Given this list of marker genes MYH3, MYL4, MYL9, MYO3A, MYO7B, MYH9, MYL3, MYO19, DYNLL2, MYO1G, MYH7B, MYH2, MYH16, MYH10, MYH14, MYO1E, MYO1H (myosin IH), CGN, MYH7, MYH11, MYO9A (myosin IXA), MYO9B, MYL5, MYO6, MYH4, MYL7, MYO5A, MYO1F, LIMCH1, MYL12A, BMF, MYO10, MYO5B, MYL11, MYO1C, MYO15A, MYH8, MYH15, MYO7A, MYO18B, MYL6, MYO16 (NCBI Gene Id 23026), CGNL1, MYH6, MYH13, MYH1, MYO1A, MYO5C, MYO1B, MYL12B, MYO3B (NCBI Gene Id 140469), MYL6B, MYO1D, MYL2, CCDC102A, MYL1, MYO18A, here is a description of the gene set: Human Gene Set: GOCC_MYOSIN_COMPLEX A protein complex, formed of one or more myosin heavy chains plus associated light chains and other proteins, that functions as a molecular motor; uses the energy of ATP hydrolysis to move actin filaments or to move vesicles or other cargo on fixed actin filaments; has magnesium-ATPase activity and binds actin. Myosin classes are distinguished based on sequence features of the motor, or head, domain, but also have distinct tail regions that are believed to bind specific cargoes. species: Homo sapiens